Given this list of marker genes ATP7A, SLC11A1, PDZD11 (PDZ domain containing 11), ATOX1, here is a description of the gene set: studied in species Homo sapiens part of: Antimicrobial peptides Essential metal ions act as co-factors that enable enzymes to catalyse a wider range of chemical transformations than would be achievable using solely organic catalysts. The precise metal requirements of organisms vary between species, environmental niches, metabolic states and circadian rhythms. <br>Metals are required cofactors for numerous processes that are essential to both pathogen and host. They are coordinated in enzymes responsible for DNA replication and transcription, relief from oxidative stress, and cellular respiration. However, excess transition metals can be toxic due to their ability to cause spontaneous redox cycling and disrupt normal metabolic processes. Vertebrates have evolved intricate mechanisms to limit the availability of some crucial metals while concurrently flooding sites of infection with antimicrobial concentrations of other metals. <br> Both pathogens and hosts have complex regulatory systems for metal homeostasis. Understanding these provides strategies for fighting pathogens, either by excluding essential metals from the microbes, by delivery of excess metals to cause toxicity, or by complexing metals in microorganisms. Reactome Pathway: Ion influx/efflux at host-pathogen interface